The following is a description of a gene set: Human Gene Set: HP_ABNORMAL_VISUAL_ELECTROPHYSIOLOGY species: Homo sapiens Abnormal visual electrophysiology, and this is the list of marker genes: TIMM8A, NOTCH3, PDE6G, KIF21A, CEP104, GUCA1B, PCYT1A, CNGB3, KIZ, TTC8, MT-ATP6, SLC25A22, GPR179, OPN1MW, ALG3, FOXC1, IDH3A, RAB18, ZNF408, TULP1, TNFSF11, BBS1, BBS2, USH2A, AGBL5, PRPS1, IMPG1, SNF8, FSCN2, SCLT1, NYX, RDH12, BBS7, CABP4, MT-ND4, SPATA7, MT-ND4L, GRK1, CNGA3, IDH3B, OFD1, LCA5, PPT1, NMNAT1, DHX38, CHM, BBIP1, MECR, MT-CO1, ARL6 (NCBI Gene Id 84100), CLN8, ATF6, MFN2, BBS12, GALC, SCAPER, USH1C, RGR, FAM161A, TUB, POMGNT1, PRPF4, TUBB3, ESPN, RPGR, RDH11, PDE6A, GNAT2 (NCBI Gene Id 92084), SLC7A14, MFRP, MPDU1, POC1B, RP2, DNAJC30, HADHA, RD3, FLVCR1, NUP54, GUCA1A, CEP78, KCNJ13, CFAP410, REEP6, LRAT, PDE6H, AHI1, TLCD3B, POLG, DRAM2, GNB5, CACNA2D4, TRIM44, BBS9, PLA2G6, CWC27, UCHL1, RHO, NDUFS4, DNM1L, RPGRIP1, RS1, PRPF31, MKKS, UNC119, PEX12, CEP19, CNGA1, ZNF699, IDS, TTLL5, NEK2, RAB3GAP2, PRPF3, CLN3, SAG, TIMP3, ARSA, RLBP1, IFT140 (intraflagellar transport 140), LRIT3, TRIM32, TCIRG1, AGK (acylglycerol kinase), PCDH15, IFT172, CDHR1 (cadherin related family member 1), ITPR1, IFT88 (NCBI Gene Id 8100), ERCC8, RNF216, SNRNP200, CNGB1, ZNF513, VSX1, ZNHIT3, MT-ND6, COX6B1, KLHL7, MT-TS2, TTPA, NR2E3, BBS4, WHRN, CLCC1 (chloride channel CLIC like 1), SLC25A4, GDF6, ARL3, BBS10, AHR, IQCB1, NDUFS2, HARS1, COL25A1, TYR, RPE65, MCOLN1, PITPNM3, MYO7A, IFT74, BBS5, EYS, CLRN1, TUBA1A, NDRG1, CIB2, SSBP1, PCARE, GNAT1, PDZD7, RAB3GAP1, PRPF6, RAB28, PHOX2A, WDPCP, SLC24A1, USP45, PNPLA6, MERTK, EMC1, POGZ, NRL, ROM1, TBC1D20, HGSNAT (heparan-alpha-glucosaminide N-acetyltransferase, NCBI Gene Id 8119), PDE6B, CACNA1F, PRPH2 (peripherin 2), RP1, IMPDH1, IFT27, CEP290, ATXN1, ADGRV1, TRPM1, MT-CYB, PAX6, RIMS1, CRB1, ADAR, ARHGEF18, ARHGEF2, CYP4V2, IMPG2, GRM6, PROM1, ARSG, TPP1, BEST1, PDE6D (NCBI Gene Id 5147), TKFC, NUP62, DHDDS, CAPN5, RDH5, OPN1LW, PSAP, GNB3, ATP1A3, AAAS, PEX1, CRX, MT-ND2, CA4, RBP3, MKS1, AIPL1, GUCY2D, KIAA1549, CLCN7, ADAM9, TUBB2B, LZTFL1, MT-CO3, USH1G, PIEZO2, ACOX1, CC2D2A, MFF, LAMA2, MAK, HSD17B4, PRCD (NCBI Gene Id 768206), TOPORS, OPN1SW, ARL2BP, CFAP418, SDCCAG8, MOGS, LARGE1, GJC2, MT-ND1, PRPF8, RAX2, RP9, OPA1, KIF3B, NPHP1, ATXN3, TUBB4B, SEMA4A, RP1L1, CERKL, ELOVL4, PDE6C, WWOX, SPG11, ABCA4 (NCBI Gene Id 7815), MT-ND5, SUCLA2, FXN, OSTM1, ERCC6, SNX10, CDH23, CYP27A1 (NCBI Gene Id 1593)